Given this list of marker genes COX5A, LRPPRC, FBXL4, FLAD1, PUS1, MTFMT, GFM2, COA5, TRIT1 (tRNA isopentenyltransferase 1), AARS2, COX16, EARS2, MGME1, ATP5F1A, PET100, MRM2 (NCBI Gene Id 29960), COA3, TSFM, TAMM41, ISCU, QRSL1, COA6, MECR, COX4I1, PET117, TEFM, MRPS22, SCO2, AGK, SLC25A4, SUCLG1, UQCC2, TK2, SLC39A8 (solute carrier family 39 member 8), MRPL39, RRM2B, MPV17, YARS2, GTPBP3, RARS2, CARS2, MRPS14, POLG, TRMT5, NSUN3, AIFM1, VARS2, AHDC1, OPA1, TIMM22, NDUFA4, GATC, C1QBP, COX20, NARS2, MRPS25, MTRFR, SLC25A26, COX6A2, TRMT10C, MRPL12, GFM1, CHCHD10, MRPS23, DGUOK, CRLS1, MIEF2, MRPS16, COA8, here is a description of the gene set: A reduction in the activity of the mitochondrial respiratory chain complex IV, which is part of the electron transport chain in mitochondria. species: Homo sapiens Decreased activity of mitochondrial complex IV Human Gene Set: HP_DECREASED_ACTIVITY_OF_MITOCHONDRIAL_COMPLEX_IV